The following is a description of a gene set: Abnormal digestive system morphology Human Gene Set: HP_ABNORMAL_DIGESTIVE_SYSTEM_MORPHOLOGY A structural anomaly of the digestive system. studied in species Homo sapiens, and this is the list of marker genes: PEX26, HRAS, ECE1, FGFR3, SUZ12, NHP2, CDH1, POLG, WIPF1, RBPJ, DZIP1L, CASZ1, PARN, DCDC2, JAK2, CLCA4, KAT6B, KIT, EGFR, ADAMTS3, PITX2, SPAG1, ENG, ACD, EBF3, PEX16, RBM10, ALG1, WRAP53, NUP107, IL1B, BRCA1, CFTR, BBS7, MGMT, MED12, FLNA, ODAD3, PRKCZ, FKBP6, BAZ1B (bromodomain adjacent to zinc finger domain 1B), DLK1, LCT, TNFAIP3, MYC, ROS1, DRC1, MEG3, DLL1, FRAS1, ODAD2, ZFX, PEX19, PEX11B, RPS24, KEAP1, FCN3, RTTN (rotatin), ELANE, IKZF3, SMAD2, IL10RB, CRIPTO, INTU, GPR35, GTF2I, PIGL, FGF20, FH (NCBI Gene Id 83748), MINPP1, CAMTA1, OTX2, WDPCP, FANCD2, TGFB1, UBA2, COL5A1, MCIDAS, PEX14, STK36, CENPF, PIK3CA, GCLC, PTEN (phosphatase and tensin homolog), PLG, CCDC40, HFE, RARB, FGFR1, SIN3A, MYF6, AKT1, CREBBP, ELN, PTPN22, DHODH, STAT3, TLR2, COL3A1, ITGA8, EPCAM, RPS26, DHCR24, HSD3B7, UROD, RSPH3, ARHGAP31, CFAP298, WDR35, RABL3, SPEF2, GPR101, GSTM3, NFIX, ITGB4, STN1, TPRKB, RPL18, ARPC5, DNAJB13, GLIS3, DCLRE1B, CCDC28B, TUBA1A, RPS10, TWIST1, MT-ND4, PLVAP, HLA-DRB1, IVNS1ABP, CDK4, PSPH, CEP104, ALAD, F13A1 (NCBI Gene Id 2162), GALE, SERPING1, HSPG2, GDF3, VPS51, PIGV, GBA1, AP1B1, ACTA2, KRAS, EWSR1, RAD21, XIAP, FXN, BUB1B, BRCA2, STXBP2, UNC45A, NFKB1, THOC6, COMT, POR, USP9X, DNAL1, LZTS1, PLEC, SKIC3, GNB2, AIP, LYN, ARF1, TBC1D23, FREM1, FGFRL1, PEX1, LAGE3, NOD2, SON (SON DNA and RNA binding protein), MMP21, BBIP1, SLC6A14, PORCN, ICOS, COL1A1, FOXH1, PGAP3, RAB34, RNU12, SDHC, KIFBP, GREB1L, STAG2, MLXIPL, FUZ, VANGL1, SMARCD1, GDNF, F13B, HLA-DQB1, TP63, RNF31, TRAPPC11, ABL1, TP53RK, ABCD1, NPHP3, HIRA, REL, RRAS2, IGHG2, PTDSS1, IFT27, RFC2 (replication factor C subunit 2), NCF1, SERPINH1, NUP88, ACADVL, ALG9, RBCK1, FOXE1 (NCBI Gene Id 7081), IKZF1, BCL10, CEP41, EFTUD2, DHCR7, DCC, MCC, USB1, PQBP1 (NCBI Gene Id 5974), NME8, RECQL4, UBE4B, POMT1, SRC, UBR1, VPS37D (VPS37D subunit of ESCRT-I), DIS3L2, TGIF1, KIF21A, PAICS, IL10RA, LRPPRC, SDCCAG8, RPS20, BLNK, DACT1, DYRK1A, IRF2BP2, SKI, BCR (BCR activator of RhoGEF and GTPase), SMC1A, WT1, DDX3X (DEAD-box helicase 3 X-linked), IL6, SALL1, RPL11, CTC1, CDKN2C, HMOX1, CARD11, DCTN4, SYK, CDC45, B3GLCT, SF3B4, HLA-DQA1, CDC73, CTNND1, STAT1, SIX3, NCF4, ARFGEF2, ZNF423, CASP10, RAPSN, MYH3, SETD5, MSR1, LIMK1, NCF2, PTPN3, TOGARAM1, CXCR4, DYM, MEOX1, DNAH1, GLI3, MEFV, TNPO3, SUFU, KIF26A, SLC12A2, DCHS1, PALB2, MDM2, NEFH, TBX4, ATM, PRTN3, RIPK4, LTBP1, RFX6, FIG4, SMAD4, BDNF, CD81 (CD81 molecule), DSG1, ALG6, ASXL3, MID1, RNF6, JAK1, TEK, RPL8, UPB1 (beta-ureidopropionase 1), PRF1, ODC1, FOXP3, GAS1, HESX1, CDK8, PGM3, DVL3, CARMIL2, PDGFRA, CEP57, NF1, OPLAH, BAP1, PDE6D, HLA-DPA1, ESCO2, DDX6, PKHD1, PCSK1, TMEM138, TCTN2, MYCN, RPS19, FKRP, PIBF1, IL12A, GDF6, BCOR, FANCG, BUD23, LEMD3, DNAAF3, TGFB3, BAX, CEP290, SCLT1, EXT1, HEPACAM, DOCK11, ROBO1, VAC14, PEX10, PET117, SLC30A10, IRGM, SCAPER, KYNU, SLC6A5, EXT2, ZMYND10, MT-CO2, SPEN, IRF1, FASLG, WASHC5 (NCBI Gene Id 9897), MYRF, ZEB2, DGUOK, PLCG2, COL4A6, SLC10A2, KRT18, CAPN15, SLC18A3, PEX6, TMEM231, TAF6, BLM, RYR1, IARS1, ATP7A, PLA2G2A, PEX13, HNRNPK, KMT2C, MAD2L2, RPL9, SOX3, ARL3, PIK3CD, EDNRA, GTF2IRD1, KAT6A, JAK3, TNRC6B, RET, CACNA1C, ASCL1, RPGRIP1L, LARGE1, MAP3K7, POLR1B, DLL4, ERBB2, CHST14, PTPRJ, CARD8, EIF4H, LUZP1, FAS, PACS1, RPL35A, MVK, DYNC2I1, PEX3, SGO1, FANCL, CD3G, FOCAD, AURKA, CYBB, SEMA4D, COL14A1, APC2, ADAM17, FGFR2, CDON, PRMT7, SPINK5, STIL, GPHN, OTUD5, RPS28, PALLD, NFKBIA, SNAI2 (NCBI Gene Id 6591), PGAP2, TGFB2, PRDM16, GIMAP5, ERCC2, SLC9A3, NSD2, MC1R, FANCF, DICER1, CBS, ALG8, C1R, CCND1, MT-TS2, DPYSL5 (NCBI Gene Id 56896), TINF2, XRCC2, GFRA1, POLR1C, INSR, NPHP1, CAVIN1, WNT4, RPS6KA3, MAB21L1, GON7, SLC11A1, TNFRSF13B, TMEM94, STX3, ERBB3, TNFSF12, STX11, DNAAF1, CFAP221, ADA2, ALG12, SMO, CFC1, KATNIP, TTC7A, PERCC1, MLH3, LIG4, TET2, CHRNG, SEMA3C, NIPBL, SPIB, MT-CO1, ITGB2, HES7, CDKN2B, GP1BB, SALL4, PI4KA, ODAD4, LIG3, LTBP4 (NCBI Gene Id 8425), ADAMTSL2, SOCS1, CLIP2, TSR2, SETBP1, ODAD1, CCDC22, LBR, SMARCAL1, HNRNPU, TWIST2, CYP7B1, LMX1B, MTRFR, TRIP13, SLC6A8, CFAP45, NSD1, PRKAR1A, LMNA, BIN1, RPS15A, ITGA6, TBK1, NSUN2, FCGR2A, IFT172, WBP11, CSPP1, DDX59, RPL35, TERF2IP, STRA6, RPL15, RTL1 (NCBI Gene Id 651665), BBS2, KLF6, TBL2, BUB1, LMBRD1, ZAP70, GLMN, VWF, ARVCF, OFD1, SDHD, FKTN, SMAD3, EDNRB, MT-TH, MS4A1, RRM2B, G6PC3, SRP68, SYT2, DNAI1, TBC1D7, POLD1, ZNF699, MTMR14, FCHO1, WDR4, RSPH9, DOCK6, SIX6, EMC1, ATP6V1E1, BACH2, ITCH, TNFSF15, CHD8, FANCA, RREB1, LRRC56, SMAD7, STAT6, PAK2, SLC37A4, MYOD1, LRBA, COG8, TRAF7, NDUFB11, DLEC1, L1CAM, BBS12, CBY1, COL5A2, UBE2T, AAGAB, HDAC4, IPO8, FAH, DNM2, MBD4, CCNQ, GBE1, TCTN3, ISL1, SAR1B, NFKB2, CLMP, SRCAP, SREBF1, PMM2, ZMPSTE24, PPP2R5D, FARSB, PHKA2, PPP1R12A, F12, MSH3, AP2S1, CAMK2A, DSE, ATP7B, TYMS, MALT1, DNAAF6, CR2, AXIN2, TBCE, NRAS, EHMT1, BRD4, CPOX, IL2RA, PSTPIP1, FOXF1, TTR, EFEMP1, DNAH5 (dynein axonemal heavy chain 5), NOTCH1, EYA1, LAMB3 (NCBI Gene Id 3914), MIF, MT-TQ, ASXL1, CPLX1, MST1, CTNNB1, STXBP1, OSGEP, MYLK, KITLG, IL21, BICRA, HMBS, MUSK, B9D2, NME5, PIK3R1, ERCC4, RBM8A, ARNT2, CIITA, RMRP, CYBC1 (cytochrome b-245 chaperone 1), MAP1B, LAMA3, CHRM3, GAS2L2, FAT4, HPS6, ADAMTS2, CALR, ZBTB7A, TGFBR2, SDHA, TFAP2A (transcription factor AP-2 alpha), GRIP1, TTC12, GPIHBP1, WAC (NCBI Gene Id 55468), CHD7, SLC25A12, HPS1, NOTCH3, CDKN1B, BBS9, GMPPA, MTOR, ALMS1, SHH, BBS4, RPS29, WBP4, HCCS, NAA10, GTF2H5, POMT2, TGFBR1, AIRE, SIX1, SLC25A24 (NCBI Gene Id 92093), TP53, KIF12, UNC13D, FANCC, ALG3 (ALG3 alpha-1,3- mannosyltransferase), PIEZO1, TBX1, VPS35L, HLA-DPB1, RSPO2 (NCBI Gene Id 340419), FANCM, MSH2 (mutS homolog 2), PDGFRB, TMEM216, FREM2, IL12RB1, ZIC3, COL4A5, TNFRSF1A (NCBI Gene Id 8077), GATA1, MAD1L1, GREM1, SKIC2, ARL6, VARS1, PIGO, PIK3CG, STX1A, UROS, MTM1, ARMC9, LAMC2, TERT, IFT43, DDB1, PKD1, RNF43, RSPH1, NOTCH2, CDH11, WNT2B, CTHRC1, B9D1, MYH11, MT-TW, MEN1, HEATR3, AMER1, POLE, ATRX, SLCO2A1, TRIM32, MITF, ARL13B, AR, TREX1, FOXC1, DPYS, CYBA, MMP23B, HABP2, CCNO, SLX4, PDE11A (phosphodiesterase 11A), RPL31, MAFB (MAF bZIP transcription factor B), APC, CDKN1A, KIAA0753, DYNC2I2, RTEL1, RELA, MT-ND6, DOCK8, SERPINA1, CPLANE1, PAX3, SEC23B, ZFPM2, AHI1, NEDD4L, TMEM270, BBS10, MAGEL2, ATN1, SEC61A1, KIF7, PEX12, PSMB10, ASCC1, PHOX2B, TBXT, C1S, ARID1B, EXTL3, NPM1, KLLN, DYNC2H1, DNAAF5, MIR17HG (miR-17-92a-1 cluster host gene), RAD51, KIF3B, SATB2, EDN3, RPL26, DNAH9, IL1RN, MPI, DOK7, DNAAF2, MYO5B, PIK3C2A, TCF4, SEMA3E, PIGY, CC2D2A, SNRPB, FGF8, PPP2R3C, PIGN, EOGT, HLA-B, MMEL1, GLRB (NCBI Gene Id 2743), RPL5, ELF4, NUP133, FANCE (FA complementation group E), WNT7B (NCBI Gene Id 7477), NPHS1, NLRC4, LONP1, MUTYH, PLA2G4A, UBE3B, PDGFRL, RPS7, KCNN4, POLA1, PDPN, WNT9B, IDS, SLC26A9, IGKC, LRP2, DNAH11 (NCBI Gene Id 8719), SEC24C, DISP1 (dispatched RND transporter family member 1), IGHM, YRDC, LETM1, DGAT1, PHGDH, PEX5, TMTC3, NOP10, RFWD3, POLR1D, STK11, RPGR, FLCN, WAS, WFS1, HMGA2, CEACAM6, PPOX, USF3, DNAAF11 (NCBI Gene Id 23639), HDAC8, GRB10, FOXJ1, RPL27, PTCH1, MASP2, ACTG2, FBN2, DOCK2, XYLT2, POT1, GTF2IRD2, BMPR1A, RERE, AP1S1, DNAI2, CD19, MYO1H, SOX10, MT-ND1, BBS1, MNX1, TNXB, PIGW, GNA11, PYCR1, SPINT2, COX7B, CCBE1, C2CD3, JMJD1C, CTBP1, PHKG2, KDM6A, GATA6, ROR2, ATAD1, PIEZO2, MAMLD1, UFD1, MCM6, WDR73 (WD repeat domain 73), CEACAM3, MAX, IFT80, HSPA9, EFEMP2, NEK1, LZTFL1, CCDC39, TYMP, HNF1B, COL18A1, GUCY2C, RPS27, CEP120, CHN1, NXN, GPC4, STAT5B (NCBI Gene Id 6777), BRAF, MT-ND5, PEX2, KMT2D, WWOX, NEK10 (NIMA related kinase 10), ZIC2, HOXD13, SEMA4A, SHARPIN, NODAL, RPS17 (ribosomal protein S17), SAMD9, LMOD1, PIGT, FANCB, MBTPS2, MT-CO3, SRSF2, INPP5E (inositol polyphosphate-5-phosphatase E), PTPN12, LBX1, TCOF1, RIPK1, ARX, TCTN1, CBLIF, GNAS, IFT56, SLC26A3, CFAP74, RSPH4A, PAH, CD55, CFAP418, COL7A1, NTHL1, LIPA, ABCC2, TYR, GDF2, TTC8, DLC1, FLNB, GMPPB, TMEM67, TNFRSF13C, MT-TL1, CDKN2A, EP300, DNAAF4 (dynein axonemal assembly factor 4), WNT7A, PLCH1, GPC3, SCAF4, ZMYM3, KANSL1, PMS1, YY1, MKS1, KCNAB2, NRTN, MLH1, TMEM237, FERMT1, RAD51C, POU2AF1, KDM3B, GLI2, SMC3, ERMARD, ALDH18A1, BUB3, HYDIN, CEP295, COG6, SEMA3D, CISD2, PROKR2, SOX2, INAVA, IL37, GRHL2, MSH6, TOM1, FANCI, ZPR1, FLI1, ACVRL1, DNAJC30, B2M, CRKL, ABCB1, TBX3, CTLA4, NEK9, SH2B1, BBS5, CFAP300, TMEM218, HYLS1, ARPC1B, IRF5, HPGD, MAPK1, KIAA0586, DEF6, DKC1, GABRD, METTL27 (NCBI Gene Id 155368), STS, IKBKG, TWNK, MMP1, MKKS, SLC2A10 (solute carrier family 2 member 10), F5, NBN, PTPN6, MT-TF, RAC2, CHEK2, TERC, SDHB, RAD54B, GLRA1, CHD4, PMS2, FBLN5, RHBDF2, CEP19, IFT74, IFIH1, BRIP1, WNT3, PKP1